Given this list of marker genes LRR1, PLA2G4D, MAPK14 (NCBI Gene Id 1432), MTCL3, NREP, C11orf58, GPATCH2, UBASH3B, EPS8, HYCC2, C4orf46, RFTN2, C8orf34, CHSY1, SNW1, SEPTIN7, KLHL15, ACTR2, UACA, PFKFB2, FCHSD2, STX16, RBM39, HYCC1, SAMHD1, TFAP2A, FZD6, DCAF13, EFNA5 (ephrin A5), NAA30, ZMYND11, IL18BP, RYBP, KCTD3, TLCD4-RWDD3 (TLCD4-RWDD3 readthrough), MINDY2, MPZL1, ACBD7, BACH2, E2F4, PDE3A, ZDHHC20, APPBP2, SRD5A3, COMMD3-BMI1, RAB3C, B4GALNT1, MSX1, NAA16, STAU2, IDE, SMAD2, SNX1, DNAJA2, SNX2, RMI2, DZIP3, COL9A1, NOVA1, CLEC4E, SLCO4C1, RBFOX1, PEX3, CTDSPL2, ASAP1 (ArfGAP with SH3 domain, ankyrin repeat and PH domain 1), IL1RAP, MAGOHB, RIPOR2, C5orf47, EVI5, GUCY1A2, SEC62, THSD7A, RNF111, GPR83, RPGRIP1L, INSIG2, VPS54, KRTAP4-11, PARVA, CEP76, AGAP1, DENND5B, GALR1, SHMT1, TBL1XR1 (TBL1X/Y related 1), FGF13, CXCL12, WNK3, NUMB, ZBTB20, NEXMIF, NIN, HABP2, PCDH17 (protocadherin 17), MSTO1, SSBP2 (single stranded DNA binding protein 2), TMCC1, SOAT1, ANKRD36C, TUB, KRTAP4-8, XG, CPSF6, KMT2E, KDM7A, SHOC2, ARHGAP32, CNST, TMEM181, SMCO3, SMAD9, CEP57L1, HDHD2, TAF5, ZDHHC21, NUS1, ZNF92, KCNQ5, ERCC6, RAB8B, MYNN, MTMR4 (myotubularin related protein 4), DLG2, USP31, NEDD4L (NCBI Gene Id 93998), TMEM38B, GK5, F5, ANKRD36B, RNF207, HACE1, ADAM9, GCH1, BEND2, LPP, PTGFR, SAMD9, here is a description of the gene set: studied in species Homo sapiens Human Gene Set: MIR190B_3P from publication Chen Y, Wang X (PMID 31504780) Genes predicted to be targets of miRBase v22 microRNA hsa-miR-190b-3p in miRDB v6.0 with MirTarget v4 prediction scores > 80 (high confidence targets).